Given this list of marker genes Pmp22, Nme5, Rsph6a, Rsph9, Dnajb13, Iqub, Rsph1, Ropn1l, Rsph14 (radial spoke head homolog 14 (Chlamydomonas)), Rsph3b, Dydc1, here is a description of the gene set: The pairwise union of individuals for the purpose of sexual reproduction, ultimately resulting in the formation of zygotes. species: Mus musculus Mouse Gene Set: GOBP_MATING